Given this list of marker genes PLXNA4, NFIB, TSKU, WDR47, FBXO45, NR2E1, DRAXIN, here is a description of the gene set: Generation of a long process of a CNS neuron, that carries efferent (outgoing) action potentials from the cell body in one half of the cerebral cortex towards target cells in the contralateral half. This axonal process is a member of those that make up the anterior commissure, a small midline fiber tract that lies at the anterior end of the corpus callosum. Human Gene Set: GOBP_ANTERIOR_COMMISSURE_MORPHOGENESIS studied in species Homo sapiens